Given this list of marker genes Stat5b, Il2rg, Stat4, Il21r, Jak3, Stat5a, Il21, here is a description of the gene set: part of: Interleukin-2 family signaling This event has been computationally inferred from an event that has been demonstrated in another species.<p>The inference is based on the homology mapping from PANTHER. Briefly, reactions for which all involved PhysicalEntities (in input, output and catalyst) have a mapped orthologue/paralogue (for complexes at least 75% of components must have a mapping) are inferred to the other species. Reactome Pathway: Interleukin-21 signaling electronically inferred by orthology from the curated human pathway species: Mus musculus